Given this list of marker genes CNOT6, CDK2, AHR, C1orf56, NRN1, FOXI2, ECM1, KYAT3, UBA3, APELA, DOCK4, PHF20L1, SORCS1, IDH1, LMO4, GBP1, GGNBP2, PRKCQ, TRMT44, SIGLECL1, MALT1, NSD1, KLHL11, KBTBD6, CCKAR, CALML4, NUDT12, HTR2A, TIMP2, AASS, PAK4, PHLDA1, CLDN10, GTF3C2, SIRPB1, STK39, GOLGA1, SLCO5A1, MCF2L2, DAG1, CCNYL1, RIMBP2, SNX3, ZNF37A, CLCA4, CYBRD1, LYSMD3, ARID5B, STARD3NL (NCBI Gene Id 83930), TBKBP1, CLCN4, GDA, EDNRB, MANEAL, ZCCHC14, AP1G1, TNFSF9, CDNF, RBM8A (RNA binding motif protein 8A), BTBD1, RSRP1, ZNF772, UBTD2, RIMKLA, RASSF9, ABTB2, EPHA3, PRSS23, ZNF367, RASA2, HPGD, CCDC74B, REL, POF1B, SLC26A4, KAT2B, P4HA1, here is a description of the gene set: Genes predicted to be targets of miRBase v22 microRNA hsa-miR-3659 in miRDB v6.0 with MirTarget v4 prediction scores > 80 (high confidence targets). Human Gene Set: MIR3659 from publication Chen Y, Wang X (PMID 31504780) studied in species Homo sapiens